Given this list of marker genes PRKG1, IL1RL2, ARID4A, IFNAR1, PDCD1, PRKAA2, MAD2L1, CRADD, IL11RA, CDC34, TNFRSF1A, IL6R, MAGEB1 (MAGE family member B1), IL15RA, XPA, H1-4, IL18R1, TAF1, KLRC1, RIN1, RARG, KIR2DL4, RORA, TGFBR3, RARA, PMAIP1, IL9R, FADD (NCBI Gene Id 8772), MAPK7, DAXX (NCBI Gene Id 1616), IFITM1, CASP9, IFIT5, IL12RB2, CCNA1, TAL1, PPP2R5B, MAD1L1, HRAS, CASP10, CYC1, here is a description of the gene set: An imbalance between cellular apoptosis and survival may be critical for the pathogenesis of lymphoma. Therefore, the gene expression pattern in lymph node preparations from patients with mantle cell lymphoma (MCL) was compared to the pattern in nonmalignant hyperplastic lymph nodes (HLs). Oligonucleotide microarray analysis was performed comparing 5 MCLs to 4 HLs using high-density microarrays. The expression data were analyzed using Genespring software. For confirmation, the expression of selected genes was analyzed by real-time polymerase chain reaction using the RNA extracted from 16 MCL and 12 HL samples. The focus was on genes that were at least 3-fold down-regulated in MCL; in addition to the B-cell leukemia 2 (BCL2) system other apoptotic pathways were altered in MCL. The FAS-associated via death domain (FADD) gene that acts downstream of the FAS cascade as a key gene to induce apoptosis was more than 10-fold down-regulated in MCL. Furthermore, the death-associated protein 6 (DAXX) gene, the caspase 2 (CASP2) gene, and the RIPK1 domain containing adapter with death domain (RAIDD) gene, which are key genes in other proapoptotic pathways, were also decreased in the MCL samples. The suggestion is made that in addition to the known overexpression of cyclin D1, which drives entry into the cell cycle, disturbances of pathways associated with apoptosis contribute to the development of MCL. (Blood. 2001;98:787-794) from publication Hofmann WK, de Vos S, Tsukasaki K, Wachsman W, Pinkus GS, Said JW, Koeffler HP (PMID 11468180) Human Gene Set: HOFMANN_CELL_LYMPHOMA_DN species: Homo sapiens Genes down-regulated in lymph nodes from patients with mantle cell lymphoma (MCL) compared to the non-malignant hyperplastic lymph nodes.